The following is a description of a gene set: Human Gene Set: GOMF_INOSITOL_1_4_5_TRISPHOSPHATE_5_PHOSPHATASE_ACTIVITY species: Homo sapiens Catalysis of the reaction: 1D-myo-inositol 1,4,5-trisphosphate + H2O = 1D-myo-inositol 1,4-bisphosphate + phosphate., and this is the list of marker genes: INPP5A, SYNJ2, INPP5K, OCRL, INPP5B, SYNJ1, INPP5J